The following is a description of a gene set: Genes down-regulated in CD4 T helper cells Th0: 10h versus 60h. Despite their enormous importance, the molecular circuits that control the differentiation of Th17 cells remain largely unknown. Recent studies have reconstructed regulatory networks in mammalian cells, but have focused on short-term responses and relied on perturbation approaches that cannot be applied to primary T cells. Here, we develop a systematic strategy – combining transcriptional profiling at high temporal resolution, novel computational algorithms, and innovative nanowire-based tools for performing gene perturbations in primary T cells – to derive and experimentally validate a temporal model of the dynamic regulatory network that controls Th17 differentiation. The network is arranged into two self-reinforcing and mutually antagonistic modules that either suppress or promote Th17 differentiation. The two modules contain 12 novel regulators with no previous implication in Th17 differentiation, which may be essential to maintain the appropriate balance of Th17 and other CD4+ T cell subsets. Overall, our study identifies and validates 39 regulatory factors that are embedded within a comprehensive temporal network and identifies novel drug targets and organizational principles for the differentiation of Th17 cells. from publication Yosef N, Shalek AK, Gaublomme JT, Jin H, Lee Y, Awasthi A, Wu C, Karwacz K, Xiao S, Jorgolli M, Gennert D, Satija R, Shakya A, Lu DY, Trombetta JJ, Pillai MR, Ratcliffe PJ, Coleman ML, Bix M, Tantin D, Park H, Kuchroo VK, Regev A (PMID 23467089) species: Homo sapiens Human Gene Set: GSE43955_10H_VS_60H_ACT_CD4_TCELL_DN, and this is the list of marker genes: CD28, GNAO1, COPS4, CA12, NFIB (NCBI Gene Id 4781), PHTF1, B4GALT6, UBAC2, GFAP, IL1R2, MAU2, GIP, ADPGK, CASP8AP2, FBLN2, UGDH, RCAN1, ERRFI1, MYT1L, ALDOAP2, DNMT3A, CCKBR, FAAP20, SETDB1, HK1, CD36, DNTT, NAA38, ZAP70, MAF, JUNB, CDKN2D (NCBI Gene Id 1032), FCHO1 (NCBI Gene Id 23149), DEGS2, IL9, DNASE1L1, AKTIP, MRPL54, SPDEF, SERPINB2, HK2, KDM3A, NDP, PTK2B, GRK5, LORICRIN, FLNB (filamin B), TGIF1, ZNF740, NDUFAB1, KLF3, MYL3, TGFBI, ANKRD28, TSEN15, ZYX, DCTN6 (NCBI Gene Id 10671), CASP4, NR0B1, SARS1, DUSP8, GLDC, ATP5IF1, GMFG, RNF38, PFDN1, NMT2, GLUD1, KIF22, COL1A2 (collagen type I alpha 2 chain), ADIPOR2, TRAF5, GLG1, TIPIN, CFLAR, KCNN4, NF1 (NCBI Gene Id 646021), ADGRG3, FCGR2B, MIA2, LAMB2, IRF4, ELAVL4, TOP2B, VIPR1, MPV17, MAIP1, S100A6, IRS2, KRT71, N4BP1, NRP1, MKRN3, TNFAIP8, SELENOS, DVL3, GJA1, SAA2, CSNK1A1, CYTIP, CRYBG1, WDR82, CLGN, EIF2S2, DHX36, KHK, PTH, WASHC3, DCX, MYO10, TOR3A, ROBO3, SERPINB1, SLC16A1, EVX1, CNOT6L, PGM2, RPS5, ADPRM (ADP-ribose/CDP-alcohol diphosphatase, manganese dependent), PPARGC1A, CAP1, FNBP4, PPP3CA, IL10, NAP1L2, IGF1R, KDR, MCOLN2, MAP6, PLAT, CAVIN1, PISD, PTCH2, MYO5A, AP1AR, LYVE1, DUSP1, SARAF, BCL2L11, MAGEL2, TSPAN33, ECE1, HNRNPR, MAGEB4, PRDX5, PIK3CA, CNTRL, IL12B, ATXN2, MFAP4, COPE, ERO1B, PTPRE, TMEM176B, ANKZF1 (NCBI Gene Id 55139), REST, ANKH, BMP2K, HBS1L, COL5A2, CMTM3, HS1BP3, UBE2G1, BASP1, PHLDA1, SELENBP1, SPECC1 (sperm antigen with calponin homology and coiled-coil domains 1), BCL7C, PLD2, ADGRG1, CYP1B1, PURA, ALCAM (NCBI Gene Id 214), EMP2, ELMOD3, CYP11A1, RGCC, DDIT4, NCK2, NEK4, CBX6, P2RX6, PTTG1, HSBP1, OSER1, GATM, GNA13 (NCBI Gene Id 147219), SPSB1, PACRGL, FRRS1, AHNAK, CD79A, WDR20, HLA-E, C1orf174, FOSB, ADORA2B, ZFAND5, AADAT, GLIPR2